Given this list of marker genes MAPK3, GSK3A (glycogen synthase kinase 3 alpha), PIK3CA, AKT3, PIK3CD, BCL2, AKT1, IRS1, GRB2, IL4R, JAK1, SOS1, PIK3R1, SOS2, MAPK1, BAD, JAK3, GSK3B, SOCS1, RAF1, MAP4K1, PDPK1, SHC1, AKT2, IRS2, PPP1R13B, STAT6, here is a description of the gene set: Human Gene Set: SIG_IL4RECEPTOR_IN_B_LYPHOCYTES studied in species Homo sapiens Genes related to IL4 rceptor signaling in B lymphocytes